Given this list of marker genes Scn1b, Gsto1, Prkcd, Casq1, Ank3, Ndufa4, Cox17, Trpc6, Ehd3, Wnk2, Hap1 (huntingtin-associated protein 1), Lrrc26 (NCBI Gene Id 227618), Calm2, Cnksr3, Asph, Rnf207 (ring finger protein 207), Cacnb3, Fgf13, Lrrc52, Cftr, Syngr3, Akap6, Ednra, Chp1, Calm3, Sumo1, Abcb1b (ATP-binding cassette, sub-family B member 1B), Lrrc38, Stim2 (stromal interaction molecule 2), Stac2, Plcg2, Stim1, Actn2, Htt, Strit1, Coa8, Fgf14, Nppa, Nedd4l, Hspa2, Tesc, Atp1b1 (ATPase, Na+/K+ transporting, beta 1 polypeptide), Reln, Drd4, Park7, Lrrc55, Atpsckmt, Cracr2a, Kctd7, Ikbkb, Ank2, Pirt, Nipsnap2, Galr2, Adrb2, Edn1, Tcaf1, Abcb1a, Stac3, Gstm7, Atp1b3, Cacnb2, Atp2a1, Stac, Nlgn3, Wnk3, Pkd2, Atp7a, Atp1b2, Plcb1, Akap7, Akap9, Stimate, Dmd, Ctss, Slc9a1, Tescl, Jph2, Vmp1, Adipoq, Gal, Calm1, here is a description of the gene set: Mouse Gene Set: GOBP_POSITIVE_REGULATION_OF_TRANSPORTER_ACTIVITY Any process that activates or increases the activity of a transporter. species: Mus musculus